The following is a description of a gene set: Mouse Gene Set: GOMF_1_PHOSPHATIDYLINOSITOL_3_KINASE_REGULATOR_ACTIVITY studied in species Mus musculus Modulates the activity of the enzyme 1-phosphatidylinositol-3-kinase activity., and this is the list of marker genes: Pik3r1, Pik3r2, Pik3r6, Pik3r5, Pik3r3